Given this list of marker genes NKX6-2, AARS1 (alanyl-tRNA synthetase 1), ALS2, FLVCR1, VPS13A, KARS1, IFRD1, ITPR1, THG1L, UCHL1, GJC2, PI4KA, LMNB1, SPG11, SLC19A3, KIF1C, SPTLC1 (serine palmitoyltransferase long chain base subunit 1), PIGA, SPTBN1 (spectrin beta, non-erythrocytic 1), RNU12, TPP1, TMEM63A, HIBCH, POLR1A, EIF2AK2, LAMA1, SIGMAR1, BRAT1, HYCC1, ACBD5, PLP1, TTPA (alpha tocopherol transfer protein), PITRM1, HSPD1 (heat shock protein family D (Hsp60) member 1), FUS, MAG, KCNC3, here is a description of the gene set: Titubation Human Gene Set: HP_TITUBATION species: Homo sapiens Nodding movement of the head or body.